The following is a description of a gene set: from publication Yevshin I, Sharipov R, Kolmykov S, Kondrakhin Y, Kolpakov F (PMID 30445619) species: Homo sapiens Genes containing one or more binding sites for (MAFG) in their promoter regions (TSS -1000,+100 bp) as identified by GTRD version 20.06 ChIP-seq harmonization. Human Gene Set: MAFG_TARGET_GENES, and this is the list of marker genes: MIR4458HG, KEL, OR11H6, CRTAP, LINC01907, RPL5P24, BTBD9, TMCC2, BPNT1 (NCBI Gene Id 10380), EMG1, PPP1R14D, BRD9, LOXL3, ANK2 (ankyrin 2), TRBV29-1, DHX58, YJU2B, PBRM1, ACSL6, HSP90B2P, GOLGA8UP, PCYT1A, RAB6A, TSSK4, CCT6A, RPS29P16, RHOF, PI4K2A, LAMC1, ARL5A, RPSAP65, TACC1, GABPB1-AS1, IMPG1, FGF11, RNU6-1137P, SNORD32A, SREBF2, LINC00519, PSMC5, NR6A1, CPA6, VAT1, AHCTF1, PCYOX1L, ENSG00000232930 (novel transcript), UQCRH, TACC2, GSTO1, ACTG1P17, NDRG4, RACGAP1, GUCY2EP, EPHX2, SLC12A8, COX5BP3, ATPAF2, CYP1B1-AS1, CCDC159, GLB1L2, ENSG00000260763, ZNF705A, RTCA, RNU6-1, MAPRE2, ZSCAN31, ASCC1, ERMAP, PRDX1, EGF, SIPA1L1, TEAD1 (TEA domain transcription factor 1), ANXA1, SELE, NRDC, SH2D2A, LAMTOR4, SLC12A6, SRGAP2, TENT5C, APOBEC3A, AFG2B, TRUB2, CHRNA6, PSMC2, SLC38A6, CCDST, LUC7L, RN7SL296P, PPP2R2A, CELF1, MTMR2, GPC5, IKBKE, ARHGAP25, ELAPOR1, GADD45A, OR4K17, EMC1-AS1, LINC02923, PDCD6IPP2, TDH, PIAS2, USP48, RN7SKP123, GMFB, VCP, TGOLN2, GDPD5, RAB33B, CRPPA-AS1, DDX43P3, PCAT19, NR1I2, TRO, RBFOX1, TRIP6, CACNA1D, NAA10, SPG7 (SPG7 matrix AAA peptidase subunit, paraplegin), POR, ACSF2, SNORA58B, GOLGA7 (golgin A7), ZNF217-AS1, OXSM, IGLVIV-59, LINC00649, SNAPC5, RNA5SP44, KDM2B, RPSAP28, WWTR1, DENND5B, MAP1LC3B2, ZNF767P, MED8, RPS17P10, ACVR1, SPRTN, BATF2, DGKG, SNX29P2, MIR3122, GREB1, CALU, LINC01700, RAB4A, MIR106B, MTND5P24, ANO10, HNRNPH2, EFCAB7, SPTAN1, MARF1, DPH5-DT, ZBTB14, SLC9C1, MIR4710, SEPTIN7P9, PSMD3, CRIPTOP4, TPD52L1, CRPPA, GUSB, AP1AR, LINC01719, RNU2-30P, YWHAG, BACH1, SKAP2, PPP4R1L (protein phosphatase 4 regulatory subunit 1 like (pseudogene)), KCTD14 (potassium channel tetramerization domain containing 14), GCLM, MARVELD3, MIR580, EPB41, POPDC3, PLEKHM1, MTND5P33, MAFG, PCBP1-AS1, NFE2L1, HRC, IFT46, GBE1, TBCD, ENSG00000201733, ZMYND8, DVL2, CYP19A1, TRIM38, HK3, EHMT1, ALG2, SCARNA16, CYRIB, SPART, OR10X1, MRPL24, RBM17, RAB31, GNB1L, DGCR6L, PSMD7-DT, MARS2, DONSON (NCBI Gene Id 55597), PBLD, ARHGAP19-SLIT1, MYH9, MBD2 (NCBI Gene Id 8932), LMNA, MTCO1P55, MITD1, ALKBH3, RN7SKP35, COMETT, SRSF2, ALG1L13P, LINC01623, CASP4, DNA2, UPF3A, ME1, TMEM107, SLC48A1, UBL5P4, EHD1 (EH domain containing 1), LINC01151, ENSG00000255491, STX17, ENSG00000249738, PTPRC, TGFBRAP1-AS1, ITGAL, MACO1, MAS1L, RHOBTB3, TRIM27, PPT2, LINC01029, RNA5SP68, OASL2P, CNOT10, RFPL1S, LENG8, RNU6-746P, IGLVVI-22-1, SSX1, SLC38A9, RNF213, FAM81B, ABCA17P, RPL7AP47, SGK2, PCAT14, NFE2L3, TNFSF9, VWA7, GFM1, SULT1A2, WASHC4, OPA1, CREB3L1, H4C8, SDS, CIBAR1, COLQ, TNS1, HS1BP3, FOXO3, ENSG00000212589, VIPR2, CDK14, HSPB3, VIM-AS1, PRSS55, CD80, FANK1, ATP2A2, PCYT1B, POU2F1, RNU6-2, RNF5, MATN2, ENSG00000225056, PLOD2, RNF11, DMGDH, IL6, GSTA4, CCDC12, PSMB5, ZMIZ1-AS1, LTA4H, CASS4, NXPE3, TMEFF2, HMGB1P31, TUBB1, RPL7AP37, PPP2R5E (NCBI Gene Id 63385), CFAP69, KCNMB4, C22orf46P, PPIE, PDE11A, ARRDC3-AS1, CDK11A, SLC25A48, RNU6-1196P, DCAF5, UNKL, LINC01585, ENSG00000236754, SUN1, LINC02511, MYOT, NYX, TMEM14B, DCDC1, MME, KMT2D, FNDC3B, KCNH2, MRPS21, LINC01504, MYBPHL, IFT88, EFL1, PPP2R5C, LINC00470, SNX2, MTMR4, LINC01555 (long intergenic non-protein coding RNA 1555), LINC01287, LRRC8B, DLST, ARHGEF2, ACTR3-AS1, FRMD6, GLIPR1L2, MAP3K7CL, WIPF1, LINC00608, HSD17B3-AS1, ACAT1, FAM227A, SGMS1, RNVU1-14, SCAND1, RNF10, MYADM, DUSP21, SHPRH (SNF2 histone linker PHD RING helicase), TBL1X, SMARCE1P5, CLN5, CLASP1-AS1, ACIN1 (apoptotic chromatin condensation inducer 1), ATF7IP, RNU6-743P, LINC02561, RNU6-1245P, MIR548Q, ADD2, HM13, PSMA4, CDYL, RAET1E-AS1, PAQR5 (NCBI Gene Id 54852, progestin and adipoQ receptor family member 5), FN1, MLLT10, TGIF1, MIR93, PSMD11, BEND7-DT, HSP90AB1, LRRTM3, ENSG00000229720, BTN3A2, LINC03054, C16orf87, MMP9, SEL1L3, LINC02870, GABPB2, MED15, PRDX5, AP2A2, TUBA1B, YPEL5, PHB2, FBXO4, RNU6-44P, GCC2, MFSD11, SPOPL, E2F6, DHRS9, NDUFAF4, BCAS2, CASTOR3P, PDE4A, SNORD105, CRISP1, EXTL3, RTCA-AS1, H4C3, STX1A, CHD4, GADD45G, ZNF770, ENSG00000275846, LINC00431, RABGGTB, TNFRSF21, EIF2AK3 (NCBI Gene Id 9451), DERA, YWHAQ, LSM8, ATP5PBP8, HSPE1P11, RSRC2, TM2D3, CBX5, ASB8, ECI2, DIPK1A, LRIG2, ABCC5-AS1, LINC01511, AMPD3, PVT1, CTNND1, SYT17, GNG4, MRC2, AIFM2 (AIF family member 2), CFLAR-AS1, RSRC1, APOL4, DNASE2B, SMARCD3, LYRM9, C3AR1, LINC02608 (NCBI Gene Id 101929541), FCRLB, KLC1, RPS15AP6, OR2F2, TGFBR3, TMX3, UBR3, PNKD, BRD2 (NCBI Gene Id 9803), TEX11, ABCA5, RMI2, CD2AP, RN7SK, BCAN-AS2, METAP2P1, CREBZF, TPM4, PCNX4, AKR1B1, EEA1, MIR3688-2, ATP2B4, MUC20-OT1, HMGN2P34, RBM12B, UBC, PSMA6, BRF2, ABHD12, EIF5-DT, ST3GAL5, SELENOK, KCNMA1-AS3 (KCNMA1 antisense RNA 3), SCARNA21B, SECISBP2, RNU6-667P, SH2D6, MAPK6, RN7SL633P, TMEM37, BHLHE40-AS1, ANKRD61, LINC01562, LINC00343, GSTA1, RNU6-199P, BCL6 (BCL6 transcription repressor), COPS3, MSRA, ARHGAP17, HMGB3P10, ENSG00000266401, LINC00624, TPRA1, LINC01353, RNA5SP344, ADPGK-AS1, NUP214, RBM7, LINC01484, ABI2, BCL9L, RHBDD3, KRTCAP3, PTGES3P3, RNA5SP493, SRBD1, IRF2BP2, BAIAP2, FAH, RN7SKP168, CTTN, GJA1, DHX8, PARN, LTBP4, FMC1, ATP1B1, FBXO3, NUDT5, ZNRF3-AS1, CLTCL1, ZFAT, ALYREF, VCPIP1, R3HDML-AS1, ARIH2, RNF130, DNAJB2, CP, GPR148, ZNF263, TPT1P7, NCLN, SOX6, R3HDM2, DDX3ILA1, GMDS, SCARNA18B, SLC41A1, PRKAG1, TDP2, RABEPK, RABGAP1L, RERE-AS1, ADAM12, COL16A1, PSMD14-DT, ETV5, RNU6-34P, TOMM22P6, RESF1, MYO7B, RNU5D-1 (NCBI Gene Id 26830), PLEKHB2, DBF4B, MIR22HG, EIF6, KRT8, RNU6-29P, EPS8, HLA-DPB1, C1S, SLC25A53P1, ENSG00000250378, RNU6-792P, SNORA33, SLTM, HAO2, EHD4, APBB1IP, ATMIN, MEF2C-AS1, NRG4, PARD3B, SLC38A4-AS1, ETV4, ENAM (NCBI Gene Id 200), LINC00475, AKNA, ABCB9, CTNNA3, NKAIN4, PPP1R15A, ZEB2, GALNT11, LINC01829, PPP4R1, DENR, ERI2, SLC6A6, NCAM1, DYNLRB2, RFX8, LDLRAP1, TYMSOS, LARP1, PCNP, DHFR2, ARRDC3, PIK3R1, FAM161B, PHC3, SLC26A9, EHF, PRPF18, SQSTM1, DOP1A, ITGA9-AS1, MTND3P21, BCL9 (NCBI Gene Id 607), OPA3, P2RY1, PCDH12, MIR5188, OSBP2, LMBR1, ZNF326, APOO, IGF2BP3, FTX, MFSD6, PSMD14, KRT8P42, CYP4F3 (cytochrome P450 family 4 subfamily F member 3), PRPF19, SLC22A23, TGFB2, TTC22, KRT10, PIR, LAP3P1 (NCBI Gene Id 100873864), SLC4A4, ALDH1A2, NUBPL, NCOR1 (nuclear receptor corepressor 1), FAM117A, TRIM47, CLEC3B, GABARAPL1, SETD7, BEND6, ZBTB48, SHKBP1, CDKN2C, CBX6, GIPC2 (NCBI Gene Id 54810), LUZP1 (leucine zipper protein 1), TUBGCP3, G3BP1, INTS7, PSMD4, TRHR, RIPOR3, ELMO1, IGFL2-AS1, CRYM, STARD9, JPT1, LINC02694, HMGB3P24, STRIP1, SLFN12, ZNF3, SNORD19B, AK5, KRT6C, EXOSC4, MRO, MTCO1P39, DENND3, MCFD2P1, SLC27A1, LINC01398, PCIF1, ARHGEF10, ENSG00000273145, SLC35G2, LRP1B, CEP350, HNRNPD, VDR, TANC1, ZSCAN30, BRD7, CCDC73 (NCBI Gene Id 493860), PPP1R18 (NCBI Gene Id 170954), CTNNA2, MTCO1P58, LIMD1, DNM2, SEC14L1, ALDH1L1, TMEM106A, SAMSN1, SELENOP, TRBV29OR9-2, C15orf61, C1orf198, UBE3D, NQO1, RN7SL371P, TALDO1, CPNE4, ACTB, TRAFD1, DNAH9, EPS15L1, GNAL, BCAT2, SHLD2, MARVELD2, DCP1A, LINC02159, TACR2, ZNF335, HTATIP2, ENSG00000275740, MYH7B, USP10 (NCBI Gene Id 9100), SYNPO, PRECSIT, MAD1L1, C11orf71, SEC24A, ZNF451-AS1, NVL, RPL12P8, BCYRN1, ACTR3C, CLTC, CLDN5, DDX42, SEMA4C, TUBB, ZRANB2-DT, NADSYN1, LINC01270, ONECUT2, RAB5IF, SSR3, RAPGEF3, TUBA4B, SEPTIN7P13, ISCA2, KANK1, ERCC1, SNORD12B, CYP2F2P, CYB561, SLC30A5, TTI2, VILL, SNORD100, LINC01088, PRKAR2B-AS1, RAB30, PART1, RNA5SP222, ENSG00000199566, RBPJL, NAP1L4, PDHX, GPR146, RFKP5 (RFK pseudogene 5), LINC00862, HNRNPU, SETD3, C2orf68, INTS10, LYSMD3, ZFPM2, RPL6P25, LRP8, RN7SL672P, SLC39A13, IQCF2, EPSTI1, EFL1P1, PFN2, CDV3, CYYR1-AS1, NEDD1, LDHB, LIVAR, NLRP11, ZNF204P, MIR8088, PCDH9, P3H3, UGT8, MTCO1P18, NKIRAS2, LINC01031, PNPLA1, NSMAF, NMRAL2P, NBEAP2, CUZD1, RPL12P11, AP4E1, PPAN, SYNCRIPP1, CTDSPL2, RMDN3, SH3TC1, RN7SKP192, LONRF1, RPL7AP82, AGPAT3, ASPM (NCBI Gene Id 93990), B4GALT6, TCF12, CNTRL, RFFL, ABCC5, RN7SL174P, STPG1, SRRM2-AS1, LAP3P2, VMP1, S100Z, TKT, ZBTB17, HIVEP3, COX6B1P6, MAP3K4, ZBTB38 (NCBI Gene Id 79779), ZFPM2-AS1, PNLIP, SNX5, DNAI1, RNU4ATAC12P, RNU6-416P, CLUL1, ARHGEF6, TUBA4A, RASAL3 (NCBI Gene Id 64926), LINC01300, TAAR9, H2AC6, TFPI2, IGLVVI-25-1, CASKIN2, TSC22D1, ANKRD13A, SAMM50, CCDC144NL-AS1, LINC00339, PSMC1, BTN2A2 (NCBI Gene Id 10385), UBR5-DT, NUP42, FKBP9, SLC25A15P5, HELB, TPSG1, LINC02006, LYRM7, RPL31P22, C6orf47-AS1, SETD6P1, TCEANC, RETREG1, TARS1, SLC35B2, ADH4, ZFAS1, PLCG2, OAT, ARID1B, ATF6B, NUP50, CLIC2, MFSD2B, YAP1, CSNK1G1, FLJ46284, CSF1, LINC01275, LRRC41, STAT4-AS1, LINC02842, ADAMTS2, LINC01732, COL18A1-AS2, UTP11, CLCN3, SLC26A1, HRG-AS1, HOXB9, SCN9A, DOCK8-AS2, IFT172, PSMC3, BCL3, SLC2A2, TFPI2-DT, NR2F2-AS1, NFE4, KAT2B, SMIM20, DCAF10, TTC39A, SEM1, GBP6, SLC2A8, MDC1, DYNC1I2, PYGL, TRAF4, ACAP3, TRIM67, CAND1, RRM1, THAP12, DNHD1, ALDOA, STAT6, RREB1, ANKRD13C, CARD8-AS1, KEAP1, YWHAZ, GPRC5C, MIR4271, ADD3, RBM41, GSTP1, TRBV27, SPG11, SYNRG, RARS1, DENND6A, PKD1L2, CHODL, UBASH3A (ubiquitin associated and SH3 domain containing A, NCBI Gene Id 53347), ACAA2P1, NAA80, SLC44A1, SRD5A3-AS1, NUP43, SNORA80B (small nucleolar RNA, H/ACA box 80B), DEAF1, SRGAP3, SRPK2, SELL (selectin L), SLC13A4, NSD3, PRELID1P5, REPS1, CLIP4, CPEB4, CDKL1, RAB18, MKLN1, NHLRC2, RBBP4, TMEM138, ORMDL1P1, LINC01058, MIR30C1, LINC00504, NPL, PHACTR2 (NCBI Gene Id 9749), LINC01094, PTP4A2, FIRRM, CDRT8, LINC02141, NEK4, TNFAIP3, TENM4, RNU6-951P, SNX8, GPRIN2, TMIGD3, DMTN, IL1R1, RNU6-271P, ANK3, CUX1, CRYBA2, CHMP3-AS1, LINC00466, MPZ, PLEKHG3, PAX6, ZNF541, TMEM259, AKR1B10, P2RX6, FAM219A, CNRIP1, GOT2 (glutamic-oxaloacetic transaminase 2), SMOC1, TMED4, CRYGS, SULT2B1, C1orf43, SNHG21, SNF8, RNU6-323P, KMT5A, ENSG00000287636, RPS6KB1, RFESD, UOX, MIR4252 (NCBI Gene Id 100422975), KAZN, EPC2, CLN8, PCLO, CPEB1, BEND7, H2BC11, IQCH-AS1, ABCC3, HMGN2P7, SIGLECL1, TRIM69, RALY, CHD2, TAT, RFC5, LINC01339, LRP1, EIF4A3, MIR1296, CRIM1, MEIKIN, TEX50, GATAD2A, PPT1, CDC42P7, KRT128P, ANXA3, MTA3, HK1, UBOX5, LINC02846, RPL36P10 (ribosomal protein L36 pseudogene 10), USP14, ADAM9, TRMT5, USP32P1, HOXB3, IFI16, METTL9, COQ8B, CFLAR, DAXX, PATJ, SDCBPP2, RNA5SP531, ERC1, DGAT2L6, RPS6KA1, NFE2L2, RFWD3, ALX3, LAMA3, RNU6-137P, TBXAS1, RNU6-652P, SORT1, GPX2, LINC02200, EEF1AKMT3, ACSM4, ENSG00000268460, SNORD19C, SBNO1 (NCBI Gene Id 55241), AFP, NKD2, SPPL2A, POP4, FYN, ELF2, MLH1, TRAJ5, GSDMC, WDR81, SNORD45C, AHSG, SULT1A1, RGS5, MFAP3L, NID2, SLC34A3, RPL12P41, ASCC2, OXCT1, TMEM18, TVP23BP2, ADAM28, TCL6, DGUOK, GSTM4, MIR5700, C11orf40, ROPN1L, SRGAP2-AS1, RPL13AP21, CDK19, LINC02018, FCGRT, ELAVL1, GYG1, SKP2, NPM1P30, PTPRJ-AS1, MYPN, HLA-E, MAP4, TREX1, GBP2, RN7SL408P, LINC02377, KRTAP2-4, HOXB7, NCAN, SNORD12, CLIP1, PSMA3, CXXC1P1, MSI2, TCF4, BCKDHB, CHCHD2P1, GABRR3 (gamma-aminobutyric acid type A receptor subunit rho3), PAX9, NOL3, ENSG00000248187, MTCO1P15, DUSP13B, KMT5B, SEC61B, CANX, WDR36, PRPF40B, TBC1D14, C16orf46-DT, LINC01120, TREML4, CCDC158, UBE2Z, SCN2A, PLD3 (phospholipase D family member 3), TMEM167A, TXNIP, MSANTD3, ITFG2, TEKT5 (NCBI Gene Id 146279), ATP6V0A1, ATAD5, ALKBH8, RN7SKP37, UGGT1, ENSG00000240687, ABCC8 (ATP binding cassette subfamily C member 8), USP24 (ubiquitin specific peptidase 24), RNA5SP122, OGFOD2, ENPP3, RHOBTB1, EIF3A, CARHSP1, SRP54, JPH4, SOX13, ZDHHC13, LINC01610, FAM184A, MIR3198-1, OR2A1-AS1, MIR4727, PLA2G4E-AS1, SF3B3, ENSG00000273727, H2AC7, IFTAP, RPLP1P6 (ribosomal protein lateral stalk subunit P1 pseudogene 6), MYOSLID, CHMP3, RPL36AP19, CMSS1, LNCRNA-IUR, NLRC5, PEX6, BACH2, ASB9, NCOA4P1, PURB, POT1-AS1, UST-AS2, IFI44L, RNU7-55P, C4orf19, BTN3A3, TBC1D15, MAPT, BICD1, RWDD4P1, RPS8, HECTD1, CDC42BPB, RNU6-9, TTLL4 (NCBI Gene Id 9654), LNCTSI, LINC01089, NLRP4, P2RY6, TUBA1B-AS1, RNU6-218P, TRIM16L, TRMT1, GTF2F1 (NCBI Gene Id 2962), XPOTP1, MGST3, ZHX2, RERE, KLF2-DT, BCL2L13, RAPGEF2, MRPL46, USP3, ENSG00000253986, GRAMD1B, VRK2, ZNFX1, TPT1P2, CALN1, SH3TC2-DT, KIAA0319L, LINC01942, ASPSCR1, SSR1, BAG1, ENSG00000232995, FOS, LINC02420, PTK2, HCG25, WWP2, NBEAL1, AFDN-DT, RNU6-1238P, NOS3, TTC3, PRDM1 (NCBI Gene Id 639), HSD17B4, CEPT1, ZDHHC2, SLMAP, KRT126P, BOC, RNU6-370P, FTSJ3, GZF1 (GDNF inducible zinc finger protein 1), PSMB6 (NCBI Gene Id 95505), SEPTIN11, LYN, NF1, RHEB, NUMBL, ANKUB1, PRSS23, RBMXL3, MIDEAS, UBXN8, MTCO1P7, ART3, SPTA1, VEZT, PISD, SGSM3-AS1, MRPL35, CDC20B (NCBI Gene Id 166979), BNIP2, RNU6-321P, TAS2R2, SH3BP5, CROCC, ZNF862, EHHADH-AS1, IGF1R, LUCAT1, CAPN2, LIPM, TXN, OR8B9P, MTCO3P21, WRN, UBE2E3, RUBCNL, LRRFIP2, ZNF84, EGLN3, AGPAT1, ANKRD33BP1, KIDINS220 (NCBI Gene Id 57498), MED16, LINC02073, IL10, MED20 (NCBI Gene Id 9477), LRRC51, QSER1, GPC5-IT1 (GPC5 intronic transcript 1), DAB2, LEMD1, PDGFB, C17orf114, USP47, HTATSF1P2, FECH, RCOR3, SNORA11G, LINC00242 (long intergenic non-protein coding RNA 242), CCDC34, TNRC6B, DTL, LTBP1, CCDC162P, GHRL (ghrelin and obestatin prepropeptide), DYNC1LI1, EPDR1, ANKRD1, TINAGL1, LINC00630, ACOX2, NCKAP1L, TMEM243, RTL10, ISCU, MIR4766 (microRNA 4766), AXIN2, KDM2A, TVP23B, PSKH2, MIR4435-1, B4GALNT1, HGD, ARPC1A, HYAL3, KTN1, BNIP1, SETD5, SMCO4, CCDC150, TPRXL, FAM13A, FMC1-LUC7L2, RGS3 (regulator of G protein signaling 3), TOP1MT, FUT1, PTPN22 (protein tyrosine phosphatase non-receptor type 22), EMC4, LINC01588, CCDC86, ARHGEF9, STK3, MTND5P30, LINC01931, WRAP53, INO80, ARHGAP26, RPL23AP56, RELN, TDRD9, EIF1P2, RPS29P21, SAXO5, HOMER1, GTF2IP20, ABCB11, ADGRE1, MAN2A2, PTGES3, PAK1, TM2D2, ZNF277-AS1, POLI, STYK1, MYEOV, LY96, CCDC80, EIF3B, IQGAP1 (NCBI Gene Id 8826), MCMBP, EIF3JP3, RNVU1-27, PLAAT3, GSTA2, ARHGAP19, DPP8, VSIG1, FASTKD1, RN7SL326P, H2AC11, USP7-AS1, GPI, TMEM44 (transmembrane protein 44), GCNT2, ENSG00000212551, BLMH, CAPS2, GTF2I, LIN54, SLC37A4, RNASEH2B, LINC01409, GSDME, SLCO2B1, COX16, DISC1FP1, PITHD1, ANTXR2, RNU6-950P, METTL3, CS, PLAGL2 (PLAG1 like zinc finger 2), RAD52, GCK, SKIDA1, FAM47E, ANKRD10-IT1, GTF3C1, CXCL8, MLANA, CFAP299, LINC01269, DMAC2L, SLC24A3-AS1, CHID1, ITFG1, RGS20, CHIT1 (NCBI Gene Id 7831), MR1, TFE3, NUDT13, ENTPD7, BIN1, ENSG00000230704, ZC2HC1C, GRPEL2-AS1, ITGB5, SFXN5, NAT10, TANGO6, DGLUCY, BTN3A1, LINC02037, FLNB, ENSG00000226756, RNU6-1240P (NCBI Gene Id 106866914), AMBRA1, TOMM5, KCNIP2, TRIP13, BPGM, KRT18P65, CCT6B (NCBI Gene Id 10693), MTCP1, PIP4P1, LINC00887, NSA2, HPX, TIGD7, LINC00607, AKR1C3, MPHOSPH8, PLIN1, RNU4-8P, COX6B1P1, PRPSAP1, CENPJ, PDCL, DOK1, LINC00332, ANKRD40, DMBX1, RNA5SP90, FAM20BP1, TBC1D20, CARD8, XIST, RN7SL97P, VTRNA1-2, TXNDC15, FAM168B, OTOF, GNA12, AURKAP1 (aurora kinase A pseudogene 1), LBR, HOMER2, PDE4D, ALDH3A2, LINC00964, MPRIP, WDR41, EWSR1, LRRK2, SORD2P, TMC1, RNVU1-6, LIMA1, RNU6-889P, RNU2-56P, ZNF484 (NCBI Gene Id 83744), RNU6-140P, PMFBP1, TMPOP2 (thymopoietin pseudogene 2), RNU1-62P, NHSL1-AS1, CCSER2, RN7SL282P, TLN2, DDX5, FASTKD5, MIR548XHG (NCBI Gene Id 101927797), PSMD9, H2AZ1-DT, PAPSS2, LINC01914, UBR4, TBC1D22B (NCBI Gene Id 55633), APOL2, ZBTB20, LINC02599, TERF1, AHCYL1 (NCBI Gene Id 29039), SCPEP1, MIR3926-2, PTGR3, DET1, SMPD4, MRPS27, ABCA3 (ATP binding cassette subfamily A member 3), OPLAH, TMEM218, TMEM40, LINC00836, KIAA1191P3, ALKBH3-AS1, GDI2, VTRNA1-1, VIM, KBTBD2, RPS24P21, GLA, NORAD, MIR4435-2HG, SNX24, MTND5P23, HAO2-IT1, CFDP1, RHCE, RABGGTA, RBM12B-DT, GALNT16, ZNF143, TAMALIN (NCBI Gene Id 54408), IL9, API5, LINC00865, KHDC4, RNF145, MEF2C, MIR200CHG, PHKB, STK40, TEDDM3P, FGFR1OP2P1, LNP1, SNORD12C (small nucleolar RNA, C/D box 12C), IFRD1 (NCBI Gene Id 95049), CUL4B, AMBP, NECAB2, STRN4, TEX19, LINC01841, DSTNP5, FAM83E, NLRP1, MIR584, MANF, PRG3, DOCK4, MBP, RNU6-8 (NCBI Gene Id 101954278), KPNB1, LINC01258, C18orf21P1, CD59, ANGPT1, RNU6-918P, ENSG00000237813, CYP2R1, ARHGEF3, WDR59, TK2, DOHH, KRTAP12-1, MCM2, AGL, GARS1, PDIA6, WWOX, SLCO1B3-SLCO1B7, TTC17, SLC36A4, RTRAF, PLA2R1, BAZ2A (bromodomain adjacent to zinc finger domain 2A), HS6ST2, SPP1, PTGES3P1, THUMPD3-AS1, CRK, HACE1, CDK5RAP2, CCDC102B, TRPV2, CXCL13, TMEM45B, RBM27, MIR25, SZT2, UACA, HMGN2P46, ENSG00000203987, RNVU1-19 (RNA, variant U1 small nuclear 19), LINC02863, TWF1, UTRN, TMEM150B, TNRC18, SRD5A3, PCDHB16, HAUS4, TEC, KLHDC8A, PRPF38A, H4C16, LINC02057, RNVU1-2A, EFHD2, HEPH, DDX59, LYPLA1, RPLP1P10, BTBD19, CNOT7, ANGPTL6, RNVU1-7, EDDM13, DYSF, MBD5, NLK, CLCF1, RNU6-535P, PADI4 (peptidyl arginine deiminase 4), DHRS2, CLEC1B, ARHGAP15-AS1 (ARHGAP15 antisense RNA 1), PRR14L (NCBI Gene Id 84194), NREP, TENT5C-DT, MILIP, LINC01888, CLPX, RNU6-444P, RPL21P96, CCR3, LINC02543, LINC01929, TRAPPC8, PHTF1, PLEKHG1, SEC24C, GABRB3 (gamma-aminobutyric acid type A receptor subunit beta3), NQO1-DT, DNASE1L3, BLOC1S2, IL15RA, ABCF3 (ATP binding cassette subfamily F member 3), STXBP1, C1QC, AGTRAP, APOC1, INSIG2, CLASP1, SPDYA, AGBL4, CBR3-AS1, MTND5P32, CMAS (cytidine monophosphate N-acetylneuraminic acid synthetase), RPL18P10, ZKSCAN8P2, AFG3L2, FBXL13, CCKAR, SMG1, EDC4, FAM9B, LINC01925, DLGAP4, CWC25, ATP2C1, SLC6A12, NEDD4L, MEIS2, HMGN5, ABCA15P, ROR2, FHL2 (NCBI Gene Id 2274), GPSM3, MTMR3, TBRG4, NUF2, COX20, BCAT1, ZNF285CP, ABHD16A, GLG1 (golgi glycoprotein 1), UBAP2L, FER1L4, PLXDC1, MRPL48, MEF2AP1, LINC01795, LRRC47, RNU7-149P, SMYD3, TIALD, CD163L1, TMEM209, ZNF24 (zinc finger protein 24), LINC02564, PKIG, C2CD3, ADORA1, SRSF11, GTF2IP13, SNHG20, CRTC3, LINC01485, PAX8 (paired box 8), UROS, SENP7, KATNB1, MIR4531, POU6F2 (NCBI Gene Id 7968), CCL26, RNF135, SLC7A8, PRR5, C21orf58 (chromosome 21 open reading frame 58), RN7SL541P, SLC9C2 (NCBI Gene Id 284525), MIR142HG, EED, RNU6-1145P, IVNS1ABP, SMIM3, IQCF1, HMBS, VPS8, RABEP2, MAGOH2P, NBN, GLS, TRMT112, RAP1GAP2, CTTNBP2, TMEM116, ADORA3, PLA2G6, LINC01098, TXNRD1, SNU13, PSMA5, MDM2, WSCD1, CICP22, ENO1, MAPK13, RFC2, ENSG00000187185, SKINT1L, RBFA, VDAC2, SLC8B1, HIF1A, FAM149A, YY1AP1, RNU6-1091P, EIF4A1P4, NR2C1, HDAC4, PPHLN1, LINC02030, SLCO1B3 (solute carrier organic anion transporter family member 1B3), SLC38A10, MIR4435-2, MED13, ENSG00000212461 (NCBI Gene Id 124900332), PPARA, DOCK5, STON2, RASSF2, CFAP74, RN7SL304P, MYO3B-AS1, LGALS8-AS1, POLE2, RNU5A-8P, LINC02922 (NCBI Gene Id 121832816), TTLL1, EXOC4, AFG1L, RNU6-135P (RNA, U6 small nuclear 135, pseudogene), DENND4C, RTN4, SSX6P, LINC02132, PSAP, SNORD55, DUSP14, CYTH1, NDUFS8, POLR3E, RBL1, IGFBP4, SRRM1, GPNMB, RPL13A, ATM, PCGF5, STAT1, ANKRD17, SREBF1, MAK16, EPM2AIP1, ENSG00000277270, CCDC66, CALCOCO2, SNORD96B, E2F6P4, MYG1, FTCD, EVI5, SPART-AS1, IKBKG, SRPX2, JAML, RALGAPA1, TJP2, DUTP1, LINC02535, SLC41A2, ACTR1B, RNF139, SYTL2, SRI, FERMT3, RP1, SH3BP4 (NCBI Gene Id 23677), LGALS8, LINC00426, OSGIN1, SHARPIN, CYTH3, RMC1, CALCRL-AS1, SPIN1, SPATA2, TAFA2, RNU6-169P, TBL1XR1, MAILR, KCNN3, LUZP4P1, SLC16A6, VSTM5, LINC01237, PPT2-EGFL8, ADRM1, COTL1, GRB2, SLC3A2, BPTF, SOS1, TNFRSF8, NADK, SEC13P1, GP6, STX7, PCOLCE2, C14orf93, TMSB4X, TCTN1, SLC7A11, RNVU1-31, UBE4B, SKP1 (NCBI Gene Id 6500), MIR5706, ANKS1B, ALDH1A2-AS1, PDLIM5, TM9SF4, RASAL1, RPL12P38, POLB, DDX56, CLIC1, CLEC2B, APPL2, DST, MTND5P27, BCL2L11, STX2, CDH18-AS1 (NCBI Gene Id 102725105), ENSG00000227101, RPAP3, ITPR1, SRPK1, CLPB, APONP, MATN1-AS1, MSRB1, SCN8A, NME8, CNTNAP2, PCGF3-AS1, TTR, WDR1, RN7SKP116, SLC35A3, S100A2, SPTBN2, PPP2R5B (NCBI Gene Id 5526), CARINH, RNF212B, GEMIN8P4, MTCO1P28, LINC00840, LINC02052, PROSER3